Given this list of marker genes APOE, CBLN4, CDH8, SLC1A1, LAMA2, CBLN3, C1QL1, GRIN1, ACHE, CBLN2, LGI1, PRSS12, NPTX1, C1QL2, LRIT1, CBLN1, C1QL3, C22orf39, EGFLAM, COLQ, LAMA5, ADGRB3, LAMB2, NLGN1, NXPH1, here is a description of the gene set: species: Homo sapiens The narrow gap that separates the presynaptic and postsynaptic membranes, into which neurotransmitter is released. Human Gene Set: GOCC_SYNAPTIC_CLEFT